Given this list of marker genes EFHC1, PIGA, GRIN2A, FRRS1L, CHD2, CNTNAP2, GRN, here is a description of the gene set: Human Gene Set: HP_EEG_WITH_GENERALIZED_POLYSPIKES species: Homo sapiens EEG with generalized polyspikes EEG with repetitive generalized sharp transient waves of a duration less than 80 msec.